The following is a description of a gene set: from publication Chen Y, Wang X (PMID 31504780) Human Gene Set: MIR30D_3P species: Homo sapiens Genes predicted to be targets of miRBase v22 microRNA hsa-miR-30d-3p in miRDB v6.0 with MirTarget v4 prediction scores > 80 (high confidence targets)., and this is the list of marker genes: SLC27A6, RALA, GNA12, ACBD3, NEMP1, PRKAA2, AKAP5, MEOX2, SCAF4, RPL13, MTDH, GGH, ARF6, TPTEP2-CSNK1E, TMPRSS11D, CSNK1G3, PSIP1, CDKL5, FAM114A2, SELENOT, VANGL1, UBE2G1, AP4E1, NOD1, PYROXD1, CEP19 (NCBI Gene Id 84984), ARL11, HOOK1, CCDC6, MARS2, MTHFD2, TWNK, COL12A1, ZNF704, ACTR2, RGS7, ZNF566, COLEC12, ROCK2, EP300, PIAS2, IL1B, PIH1D2, PRDM10, SUV39H2, ROBO1, SGCZ, PSMD10 (proteasome 26S subunit, non-ATPase 10), ZBTB18, ASXL3, TTPAL, SP3, GBP1, SCAI, FCHO2, ZDHHC21, DAZ2, DOP1B, USP38, DNAJB4, CCDC186, CENPL, SLC25A33, CCDC184, ELK3, TMEM47, SLC5A3, RUNX1, LACTB, C8orf44, RAB8B, ELOC, INO80C, TLK2, SLC35F3, NSL1, RUNX2, STAU1, MAP3K4, PDXDC1, ZNF35, SLC6A3, NKRF, PDE12, RIF1, TUBGCP5, FAR1, KLHL11, CWF19L2, UBR5, OSBPL1A, SLC12A6 (NCBI Gene Id 9990), NR3C1, ZNF426, MRTFB, PMEL, DNAI4, VCPIP1, HS3ST5, SH3GLB1, NBEAL1, ATP9B, GOSR1, ZCCHC10, MEI4, FBXL20, MSR1, SESN3, YTHDF3 (YTH N6-methyladenosine RNA binding protein F3), BTNL9, NEGR1, UBL3, DNAJB14, CHURC1, YARS2, SEMA6D, KLHL5, DNAJB9, POU4F1, BRWD1, HIRA (NCBI Gene Id 7290), CCDC112, RGS7BP, EPGN, ZNF827, KRT6C, SMAD2, KRT10-AS1, NAA16, PCSK5, FAM20B, AAK1, CLDN14, ROR1, MINDY2, ZBTB41, CALHM5, ZEB2, MYO5A, SMG1, EOGT, CANX, TOMM20, FGF7, PRDM11, SLITRK3, RALGPS2, CDC73, FBXO22, CEP152, NABP1, CACYBP, PTPN3, TBC1D23, RNF216, SOCS6, INTS8, SUB1, AR, PCLO, OSBPL11, PIGBOS1, ATRN, RAB3IP, UBXN2B (NCBI Gene Id 137886, UBX domain protein 2B), ABHD5, WDR44, ZNF430, TSPAN13, LRCH1, ETNK1, SH3D19, CDKN1B, BCCIP, TUSC3, MNT, PAG1, SYNRG, KMT5B, TENM1, DBT, TCEAL6, UBE2J1, RBM7, SEC62, GALNT7, SBNO1, GPR180, EPAS1, TRIM33, HDX, P2RY1, SLC39A10, CREBBP, TULP4, SAMTOR, METTL4, GPR158, RANBP3L, TPR, PANK3, SERTAD2, CAST, GM2A, SEMA3C, TOB1, NPHP3, ZCCHC14, CHCHD4, ARID4A, PDK1, PAIP2, KLK10, RYR3, SESTD1, ZC3H14, ANTXR2, SGMS2, USP1, MFAP4, GUCY1A2, TNRC6B, COL4A4, CREB1, DACH1, MED12L, TXLNB, TRMT10B, SASS6, PIK3AP1, ZNF107, CALCA, RFK, YWHAE, EIF2AK1, OTUD6B (NCBI Gene Id 51633), FANCD2, NOX3, MAGT1, TPK1, HMGN4, SNX18, LRRTM2, ZFHX3, SLC36A4, CHMP1B, NAA25, MCCC2, SH3GL3, NPAT, HMGA2, ELAPOR2, IARS2 (isoleucyl-tRNA synthetase 2, mitochondrial), POU2F1, TNFSF13B, SYT4, CEP44, EXTL2, THOC2, SNAP91, MAP3K2, DEUP1, SLC12A1, VCF1, ZNF280B, SOD2, VGLL3, ITGA1, ZNF138, DLST, CCKBR, PHACTR2, STIM2, ATP11C, PALS2, B9D1, PPM1B, ZNRF3, NODAL, LCORL, IPCEF1, SRSF4, CSNK1E, GTPBP4, PRLR, ERAP1, TSHR, NCOA7, SH2D3A, FAM98A, EMC4, PIAS1, NR2C2, XPNPEP3, NHS (NCBI Gene Id 907), HYCC1, DOCK1, APC, LPGAT1, ARMC1, RNF217, PHLDA1, HSPA5, CDC40, TCP11L1, CNPY2, PPP1R3A, POGLUT3 (NCBI Gene Id 143888), GPR137C, CACNB4, SNRK, SLC10A7, OPRK1, RELT, NTRK3, CMKLR2, PHF24, GPR176, TNFAIP8L1, SOS2, CAPRIN1, GABRG2, ZNHIT6, LRP8, SYNJ2, FXR1, KRBA2, ARHGAP28, KCTD16, RUNX1T1, LSS, GFPT1 (glutamine--fructose-6-phosphate transaminase 1), TRIM72, EGR1, IGF1, SEMA3E, PTEN, PTPN21, KANSL1L, BRD8, GALNT1, RNF6, SSR1, GATC, NAPG, CEP350, SS18, MYSM1, NPY2R, CDKL2, NUFIP2, CAV1, TEAD1, AKT3, STK38L, SPIRE2, RNF141, CCDC80, RBM45, MRPL30, ADAMTS5 (NCBI Gene Id 11096), EPS8, DIP2B, RCN2, YPEL5, PSD3, ADA, SYT14, DHFR, UFSP2, HOXB7 (homeobox B7), APOBEC3A, PRPH2, MYO5C, COCH, HS3ST1, PLEKHH1, ECM2, RB1, SCAF11, CCN3, SLITRK6, MAP1B, KMT2A, PCDH17 (NCBI Gene Id 27253), DTNA, FAM171B, C5orf24, PDK4, RTP4, GPRASP2